The following is a description of a gene set: Genes down-regulated in comparison of CD2+ plasmacytoid dendritic cells (DC) versus CD2- cells. Human Gene Set: GSE15215_CD2_POS_VS_NEG_PDC_DN studied in species Homo sapiens Plasmacytoid dendritic cells (pDCs) are key regulators of anti-viral immunity. They rapidly secrete IFN-alpha and cross-present viral antigens thereby launching adaptive immunity. Here we show that activated human pDCs inhibit replication of cancer cells, and kill them in a contact dependent fashion. Expression of CD2 distinguishes two pDC subsets with distinct phenotype and function. Both subsets secrete IFN-alpha and express Granzyme B and TRAIL. CD2high pDCs uniquely express lysozyme and can be found in tonsils and in tumors. Both subsets launch recall T cell response. However, CD2high pDCs secrete higher levels of IL12 p40, express higher levels of co-stimulatory molecule CD80 and are more efficient in triggering proliferation of naïve allogeneic T cells. Thus, human blood pDCs are composed of subsets with specific phenotype and functions. from publication Matsui T, Connolly JE, Michnevitz M, Chaussabel D, Yu CI, Glaser C, Tindle S, Pypaert M, Freitas H, Piqueras B, Banchereau J, Palucka AK (PMID 19454677), and this is the list of marker genes: TBC1D8, SDHA, CAPZB, PTEN, WDR37, GTF2H1, SMPD3, NEK1, SCRN1, PIK3CA, GOT1, UTP11, ELAVL1, UCK2 (uridine-cytidine kinase 2), NEK3, PRKCD, AIFM1, LMBRD1, RANBP1, LMBR1L, CEP135, DBI, GADD45B, PPP2R5A, GABPA, PPP2R5C, ZDHHC24, LAPTM5, NAE1, IL10RB, USP39, LCAT, MFF, GIMAP6, MUL1, DNAJB4, JTB, NAGLU, UGP2, DHX8, ERAP2 (endoplasmic reticulum aminopeptidase 2), TFRC, SCPEP1, FBP1, ITM2C, TMEM109, ETV3, TAX1BP1 (NCBI Gene Id 8887), WDR26 (NCBI Gene Id 80232), AP1G1, AFTPH, THAP11, TENT4A, GORASP1, BST2, LBHD1, TGDS, LMNB2, RARS1, EXOSC9, UBE2L6, TAF7L, TMEM70, BAG5, PCNT, DDX50, CHPF2, SC5D, TEX2, TMEM41B, JADE1, EFCAB14 (EF-hand calcium binding domain 14), NPC2, LRRC42, GSN, TFB1M, TUT4, SNX6, MRPL28, ACYP1, FAM98A, NMI, MAPKAPK5-AS1 (NCBI Gene Id 51275), TAF5L, COQ6, CLMN, MRPS7, UBE2H, ARIH2, SDHAF3, PIKFYVE, GCFC2, STAT3, MRPS22, RPLP1, MTF1, ATMIN, PSMD6, IRF7, RAP1B, RBMS1, MRPL15, AKAP9, TLR7, ARHGAP19, FECH, KANK1, ZNF394, BRWD1, RPP14, BTN2A1, COQ9, IDI1, MAPK14, KIF24, RTN3, CYP2R1, ZFP64, PAN2, NFKB1, PSMG2, TBL1XR1, PHB1, TNKS2, NCK1, HAUS6, PSENEN, BIN2, SERTAD3, RPL3, DCAF11, TRAF2, CFAP45, SHQ1, HERPUD1, GLUD2, ENSA, HIRA, USP15, ARHGEF7, ELMO2, C2CD2, TNKS, SRSF10, TRAPPC10, PECAM1, FBXW4, ATP2A1, RUBCNL, SLC9A6, VPS39, ZFC3H1, DCP1A, CREB3, PSMA6, GFI1, ID1, ODR4, RALY, C6orf120, KCTD5, STX4, CA2, RHOA, HCG9, RPS16, SUPT20H, CLTC, NELL1, CDYL, MOCS2, C21orf91, DLG1, PARP6, TUBG2, SF3B1, RNF139, SEMA4D (NCBI Gene Id 349236), POGK, ENO1, VAMP5, BET1, COBLL1, EBP, PRKCH, PCM1, CSTF3, MYH3, ZDHHC17, GOLGA4, CDC123, MAGED1, SELENOT, IGBP1 (NCBI Gene Id 3476), ERGIC3, POLR2B, MAGEB3, ODC1, PTP4A1, TMEM50B